The following is a description of a gene set: species: Mus musculus Genes predicted to be targets of miRBase v22 microRNA mmu_miR_2861 in miRDB v6.0 with MirTarget v4 prediction scores > 80 (high confidence targets). from publication Chen Y, Wang X (PMID 31504780) Mouse Gene Set: MIR_2861, and this is the list of marker genes: Bsdc1 (BSD domain containing 1), Sgcd, Slc9a9, Mark2, E2f2, Arhgef4, Btn2a2, Lrrc41, Mthfd1, Ptprt, Chd5, Rdh8, Gm14137, Endod1, Spryd3, Tlr5, Acadvl, Zer1, Ppp1ca, Chtf8, Chad, Btbd9, Lamp5, Zmym3, Irak1, Lats1, Kcnd1, Lhfpl2, Btf3l4, Spns1, Ovol2, Nat8l, Rab43, Zfp704, Cad, Arhgdia, Nek6, Fam168a, Anks1, Cnbp, Zfta, Sema4g, Rrbp1